Given this list of marker genes PAX2, WNT9B, SOX9, WNT4, PAX8, SOX8, here is a description of the gene set: Human Gene Set: GOBP_METANEPHRIC_TUBULE_FORMATION species: Homo sapiens The developmental process pertaining to the initial formation of a metanephric tubule.